Given this list of marker genes CFH, CFHR1, CFHR3, CFI, CFB, here is a description of the gene set: Decreased circulating complement factor B concentration Human Gene Set: HP_DECREASED_CIRCULATING_COMPLEMENT_FACTOR_B_CONCENTRATION species: Homo sapiens Concentration of the complement component factor B in the blood circulation below the lower limit of normal.